Given this list of marker genes Ubqln2, Tmem67, Rnft1, Cav1, Usp19, Sgta, Rnf185, Aqp11, Bcap31, Bag6, Ubxn1, Ubxn2a, Ubqln1, Ern1, Stub1, Tmem259, Eif2ak3, Svip, Usp13 (NCBI Gene Id 99731), Eif2a, Usp25, Tmx1, Usp14, Atxn3, Wfs1, Xbp1, Rnft2, Herpud1 (NCBI Gene Id 64209), here is a description of the gene set: Mouse Gene Set: GOBP_REGULATION_OF_ERAD_PATHWAY studied in species Mus musculus Any process that modulates the frequency, rate or extent of ERAD pathway.